Given this list of marker genes C2cd4d, Spi1, Tnrc18, Ceacam1, Ceacam2, Zbtb5, here is a description of the gene set: Mouse Gene Set: MIR_1946A studied in species Mus musculus Genes predicted to be targets of miRBase v22 microRNA mmu_miR_1946a in miRDB v6.0 with MirTarget v4 prediction scores > 80 (high confidence targets). from publication Chen Y, Wang X (PMID 31504780)